The following is a description of a gene set: electronically inferred by orthology from the curated human pathway studied in species Mus musculus part of: G2/M Checkpoints Reactome Pathway: G2/M DNA replication checkpoint This event has been computationally inferred from an event that has been demonstrated in another species.<p>The inference is based on the homology mapping from PANTHER. Briefly, reactions for which all involved PhysicalEntities (in input, output and catalyst) have a mapped orthologue/paralogue (for complexes at least 75% of components must have a mapping) are inferred to the other species., and this is the list of marker genes: Ccna1, Ccnb1, Wee1, Cdk1